The following is a description of a gene set: Reactome Pathway: RNA polymerase II transcribes snRNA genes part of: RNA Polymerase II Transcription species: Homo sapiens Small nuclear RNAs (snRNAs) play key roles in splicing and some of them, specifically the U1 and U2 snRNAs, are encoded by multicopy snRNA gene clusters containing tandem arrays of genes, about 30 in the RNU1 cluster and about 10-20 in the RNU2 cluster (Van Ardsell and Weiner 1984). Whereas U6 snRNA genes are transcribed by RNA polymerase III, U1,U2, U4, U4atac, U5, U11, and U12 genes are transcribed by RNA polymerase II. Transcription of the U1 and U2 genes has been most extensively studied and the other snRNA genes as well as other genes with similar promoter structures, for example the SNORD13 gene, are inferred to be transcribed by similar reactions. The snRNA genes transcribed by RNA polymerase II are distinguished from mRNA-encoding genes by the presence of a proximal sequence element (PSE) rather than a TATA box and the presence of the Integrator complex rather than the Mediator complex.<br>The snRNA genes are among the most rapidly transcribed genes in the genome. The 5' transcribed region of the U2 snRNA gene is largely single-stranded during interphase and metaphase and chromatin within the transcribed region is cleared of nucleosomes. Transcriptional activation of the RNA polymerase II transcribed snRNA genes begins with binding of transcription factors to the distal sequence element (DSE) of the promoter. The factors, which include POU2F1 (Oct-1), POU2F2 (Oct-2), ZNF143 (Staf) and Sp1, promote binding of the SNAPc complex (also known as PTF and PBP) to the PSE. SNAPc helps clear the gene of nucleosomes and recruits initiation factors (TFIIA, TFIIB, TFIIE, TFIIF, and snTAFc:TBP) which recruit RNA polymerase II. Phosphorylation of the C-terminal domain (CTD) of RNA polymerase II by CDK7 recruits RPAP2 and the Integrator complex, which is required for later processing of the 3' end of the pre-snRNA transcript. The Little Elongation Complex (LEC) also appears to bind around the time of transcription initiation. As transcription proceeds, RPAP2 dephosphorylates serine-5 and P-TEFb phosphorylates serine-2 of the CTD. As transcription reaches the end of the snRNA gene serine-7 of the CTD is phosphorylated. These marks serve to bind protein complexes and are required for 3' processing of the pre-snRNA. After transcription proceeds through the conserved 3' processing sequence of the pre-snRNA the Integrator complex cleaves the pre-snRNA. Transcription then terminates downstream in a less well characterized reaction that requires elements of the polyadenylation system., and this is the list of marker genes: GTF2F2, GTF2E2, RNU12, SRRT, TAF6, ELL, ZNF143, INTS4, PCF11, NCBP2, POLR2F, RPRD1B, POLR2L, ICE2, RNU5A-1, TAF5 (TATA-box binding protein associated factor 5), RPRD2, CDK9, SNAPC3, INTS9, POLR2I, TAF9, CCNT2, RPRD1A, POLR2A, RNU11, TAF13, POLR2G, POLR2K, INTS5, TAF11, POLR2J, RNU4-1, RNU2-1 (RNA, U2 small nuclear 1), INTS14, ZC3H8, NCBP1, ELL3, ELL2, CCNK, RNU1-1, SNAPC2 (small nuclear RNA activating complex polypeptide 2), POLR2C, PHAX, POLR2E, INTS12, TBP, SUPT4H1, GTF2A1, INTS7, NABP2, SP1, CCNT1, NABP1, INTS3 (integrator complex subunit 3), GTF2B, SUPT5H, RPAP2, ICE1, INTS2, SNAPC1, SNAPC4, INTS13, INTS1, TAF8, SNAPC5, INTS11, POU2F2 (POU class 2 homeobox 2), CDK7, GTF2A2, INTS10, RNU4ATAC, INTS8, GTF2E1 (general transcription factor IIE subunit 1), POLR2D, INTS6, SSU72, POLR2B, GTF2F1, POLR2H, POU2F1